The following is a description of a gene set: Pathway Definition from KEGG: IGF1 -> IGF1R -> PI3K -> PIP3 -> AKT -> IKK -> NFKBIA -> NFKB IGF-IGFR-PI3K-NFKB signaling pathway. Pathway ID: N00182. Pathway type: Reference. Pathway class: nt06214 PI3K signaling. Human Gene Set: KEGG_MEDICUS_REFERENCE_IGF_IGFR_PI3K_NFKB_SIGNALING_PATHWAY species: Homo sapiens, and this is the list of marker genes: CHUK (component of inhibitor of nuclear factor kappa B kinase complex), IKBKB, PIK3CD, PIK3CB, IGF1R, AKT2, NFKB1, AKT1 (NCBI Gene Id 207), AKT3, IGF1, RELA, IKBKG, PIK3CA, NFKBIA